The following is a description of a gene set: Genes predicted to be targets of miRBase v22 microRNA hsa-miR-6754-5p in miRDB v6.0 with MirTarget v4 prediction scores > 80 (high confidence targets). Human Gene Set: MIR6754_5P from publication Chen Y, Wang X (PMID 31504780) species: Homo sapiens, and this is the list of marker genes: SPRR2B, GREM1, FLOT2, SDC3, GLRA4, TRIB2, BCORL1, AGO1, PCYT1A, SHISA7, CLCN6, RAPGEFL1, FAHD2B, TRIP6, BBS1, TNNI1, TOM1L2, ZBTB34, HS3ST2, NCCRP1, HTR3E, NIBAN2, RPH3A, CD82, CNTN2, INSM2, NFAM1, GIT2, STN1, SPRR2A, ATP1B2, RAPGEF1, EXOC3L2, MS4A18, TRIP12, SV2C, ERCC6L2, RAP1GAP2, NYNRIN, OSBP, GADD45A, MAPKBP1, ABHD2, FCHSD1, B3GLCT, EIF4EBP2, GXYLT1, IL17RD (interleukin 17 receptor D), NMUR1, CDK14, KIAA1671, SLC6A6, ZNRF1, ADAM19, PRSS16, PDE7B, MFRP, MITF, TDO2, DDB1, LINC03040, FAM222B, PRRT2, CCL22, KMT2A, NBL1, OPRM1, SPRR2E (NCBI Gene Id 6704), TBC1D8B, KRTAP5-2, TBC1D20, SKI, TTC39C, SPINT3, ZBTB4, ARL17A, ZNF444, TMEM183A, SMG6, TMEM138, SLC6A17, NPR3, ASTN1, TAP2, CDK12, HTR4, IKZF1, ZDHHC9, ARHGEF11, ALX4, TPP1, MYLK4, KRTAP5-10, DUSP3, NGEF, HTR3C, SMARCD1, NFAT5, PSMD9, RAB3B, MAP1A, FANCC, SUFU, C10orf105, PRICKLE1, KBTBD13, PIGZ, VWA5A, CNIH4, KCNE1, IFFO2, SNRPD3, ZDHHC3, WFDC10B, GANC, MEF2A, KCTD7, LINC02873, MTCL2, NR1D2, ESAM, SATB2 (NCBI Gene Id 80104), KDM4E